The following is a description of a gene set: Human Gene Set: HAHTOLA_CTCL_PATHOGENESIS from publication Hahtola S, Tuomela S, Elo L, Häkkinen T, Karenko L, Nedoszytko B, Heikkilä H, Saarialho-Kere U, Roszkiewicz J, Aittokallio T, Lahesmaa R, Ranki A (PMID 16914566) studied in species Homo sapiens Differentially expressed genes relevant to pathogenesis of cutaneous T cell lymphoma (CTCL). PURPOSE: Increased production of Th2 cytokines characterizes Sezary syndrome, the leukemic form of cutaneous T-cell lymphomas (CTCL). To identify the molecular background and to study whether shared by the most common CTCL subtype, mycosis fungoides, we analyzed the gene expression profiles in both subtypes. EXPERIMENTAL DESIGN: Freshly isolated cells from 30 samples, representing skin, blood, and enriched CD4(+) cell populations of mycosis fungoides and Sezary syndrome, were analyzed with Affymetrix (Santa Clara, CA) oligonucleotide microarrays, quantitative PCR, or immunohistochemistry. The gene expression profiles were combined with findings of comparative genomic hybridization of the same samples to identify chromosomal changes affecting the aberrant gene expression. RESULTS: We identified a set of Th1-specific genes to be down-regulated in Sezary syndrome as well as in a proportion of mycosis fungoides samples. In both Sezary syndrome and mycosis fungoides blood samples, the S100P and LIR9 gene expression was up-regulated. In lesional skin, IL7R and CD52 were up-regulated. Integration of comparative genomic hybridization and transcriptomic data identified chromosome arms 1q, 3p, 3q, 4q, 12q, 16p, and 16q as likely targets for new CTCL-associated gene aberrations. CONCLUSIONS: Our findings revealed several new genes involved in CTCL pathogenesis and potential therapeutic targets. Down-regulation of a set of genes involved in Th1 polarization, including the major Th1-polarizing factor, TBX21, was for the first time associated with CTCL. In addition, a plausible explanation for the proliferative response of CTCL cells to locally produced interleukin-7 was revealed., and this is the list of marker genes: TBX21, GZMB, IL7R, NKG7, CCL5, IL2RB, XCL1, CD52, TXK, MS4A4A, KIR3DL2, LILRA5, S100P, VAV3, DLG5